Given this list of marker genes MAML1, EP300, HES5, MAML3, MAMLD1, NOTCH2, RBPJ, HES1, CREB1, GZMB, FCER2, MAML2, here is a description of the gene set: Reactome Pathway: NOTCH2 intracellular domain regulates transcription part of: Signaling by NOTCH2 studied in species Homo sapiens In the nucleus, NICD2 forms a complex with RBPJ (CBF1, CSL) and MAML (mastermind). NICD2:RBPJ:MAML complex activates transcription from RBPJ-binding promoter elements (RBEs). Besides NICD2, RBPJ and MAML, NOTCH2 coactivator complex likely includes other proteins, shown as components of the NOTCH1 coactivator complex.<br><br> NOTCH2 coactivator complex directly stimulates transcription of HES1 and HES5 genes, both of which are known NOTCH1 targets.<br><br>The promoter of FCER2 (CD23A) contains several RBEs that are occupied by NOTCH2 but not NOTCH1 coactivator complexes, and NOTCH2 activation stimulates FCER2 transcription. Overexpression of FCER2 (CD23A) is a hallmark of B-cell chronic lymphocytic leukemia (B-CLL) and correlates with the malfunction of apoptosis, which is thought be an underlying mechanism of B-CLL development. The Epstein-Barr virus protein EBNA2 can also activate FCER2 transcription through RBEs, possibly by mimicking NOTCH2 signaling.<br><br>NOTCH2 coactivator complex occupies the proximal RBE of the GZMB (granzyme B) promoter and at the same time interacts with phosphorylated CREB1, bound to an adjacent CRE site. EP300 transcriptional coactivator is also recruited to this complex through association with CREB1. NOTCH2 coactivator complex together with CREBP1 and EP300 stimulates transcription of GZMB (granzyme B), which is important for the cytotoxic function of CD8+ T-cells.<br><br>There are indications that NOTCH2 genetically interacts with hepatocyte nuclear factor 1-beta (HNF1B) in kidney development and with hepatocyte nuclear factor 6 (HNF6) in bile duct formation, but the exact nature of these genetic interactions has not been defined.<br><br>